Given this list of marker genes DOCK8, CRKL, CORO1A, CD200, APP (amyloid beta precursor protein), SPNS2, CD69, TMEM102, ADAM8, XCL1, ECM1 (NCBI Gene Id 1893), CCL21, ITGA4, SELENOK, CD99L2, LGALS9, CCL20, RHOA, ADAM10, ITGB3, P4HB, CCR6, CXCL10, ASCL2, IL27RA, WNT5A, TNFRSF14, FADD, STK39, MED23, APOD, RIPOR2, CXCL12, LRCH1 (NCBI Gene Id 23143), TNFSF14, RIPK3, ABL1 (NCBI Gene Id 25), WNK1, AIRE, CRK, PYCARD, GPR15LG, OXSR1, CXCL13, ADAM17, CCL5, CCR2, AIF1 (NCBI Gene Id 9471), SPN, S100A7, CD200R1, ABL2, here is a description of the gene set: Human Gene Set: GOBP_REGULATION_OF_T_CELL_MIGRATION Any process that modulates the frequency, rate or extent of T cell migration. studied in species Homo sapiens